Given this list of marker genes Fap, Gm14033, Mir6335, Gm13489, Gm22298, Gca, Kif5c, Gm13620, Gm13566, Gm13569 (predicted gene 13569), Gm13559, Gm24549, Gm13544, 5330411J11Rik, Idi1-ps1, Gm13600, Gm13546, Rbms1, Gm13602, Grb14, Gm13551, Tank, Gm13472, Rnd3, Kcnh7, Acvr1c, Neb, Mir7224, Gm25215, Ccdc148, Gm13497, Gm13501, Gm13555, Gm14035, Gm33594, Gm22020, Gm13590, Gm13578, Gm13484, Gm13493, Gm25489, Cytip, Epc2, Upp2, Gm25898, Slc38a11, Rbm43, Pla2r1, Gm14032, Scn2a, Lypd6b, Gm14034, Gm13490, Rpl35-ps1, Scn1a, Gm13572, Tbr1, Slc4a10, Gm13508, Mbd5, Gm13596, Gm23315 (predicted gene, 23315), Gm13615, Scn9a, Stk39, Gm13575, Scn7a, Gm13592, Ldha-ps, Galnt3, Gm23328, Gm23505, Gm13580, Atp5k-ps4, Rif1, Prpf40a, Dapl1, Kcnj3, Gcg, Stam2, Gm13601, Ermn, Gm13481, Mir6337, Ifih1, Ly75, Gm13500, Gm13534, Gm13485, Gm13527, Gm13570, Gm13593, Gm13533, Gm25388, Gm13495, Baz2b, Gm13531, Tas2r134, Gm13521, Gm13510, Gm13629, Gm13561, Arl6ip6, Gm17409, Gm13483 (predicted gene 13483), Gm13517, Cobll1, Gm13549, Gm13480, Nmi, Lypd6, Gm13552 (NCBI Gene Id 100045592), Arl5a, Mmadhc, Rpl10a-ps4, Tanc1 (NCBI Gene Id 66860), Galnt5, Wdsub1, Gm13576, Marchf7, Cacnb4, Orc4, Gm13599, Mir195b, Gm13503, Gm13541, A930012O16Rik, Gm13522, 1700057H21Rik, Bloc1s2-ps, Gm13505, Gm13487, Acvr2a, Csrnp3, Scn3a, Gm13535, B3galt1, Gm13567, Psmd14, Fign, Gm13630, Pkp4, Dpp4, Gm13598, Gm13582, Itgb6, Gm13607, Ttc21b, Gm13491, Gm13604, Gm24138, Tnfaip6, Nr4a2, Gm13494, Ap2m1-ps, A430018G15Rik, Gm13594 (predicted gene 13594), Galnt13, Gm13583, Xirp2, Gm25338 (NCBI Gene Id 115489639, predicted gene, 25338), Gm13545, Cd302, Gm13498 (predicted gene 13498), 4930555B11Rik, Rprm, BB557941, Fmnl2, Gm13571, Acvr1, Gpd2, here is a description of the gene set: studied in species Mus musculus Mouse Gene Set: chr2C1